Given this list of marker genes SFRP4, GPATCH2, CALD1, PLPP1, DUSP6, PRPSAP2, OSTF1 (osteoclast stimulating factor 1), CLECL1P, AP1S2, HECW2, TMEM192, S100P (NCBI Gene Id 6286), PTPRN2, SLC25A15, GAB2, PTGER2, CELF6, MACROH2A2, RXRA, SAMD3, RNF213-AS1, IKZF2, LIMS2, CLDN5, HRH1, TMEM71, TESPA1, PTEN, ABHD6, NT5C3B (NCBI Gene Id 115024), IL4R, ALX4, TIMP1, ETV3, KRT1, CCDC178, IL10RB, NNT, DLG5, RUNX1, PTPN14, RRS1, CCNT2-AS1, PECAM1, LINC00265, C1QTNF7, DIPK1A, SPINDOC, RNF125, ABHD8, VSIG10L, DACH1, TPRG1, BIN2, LONRF2, CDH1, SMYD2, CEACAM5, SPINT2, DCBLD1, ADAP1, TBC1D22A-AS1, C12orf75, PDCD4-AS1, BCL2A1, FAM171A1, DYNC2LI1, CAMSAP3, MMP1, FRY-AS1, PABPC4L, NSUN3, LETR1, CFAP97D1, CES4A, PPP1R14A, TAOK1, NMB, MID1, ACBD5, EXOC3, OXCT1, ENSG00000237250, ADAM29, NXN, TNNI3K, HMGCS2, EVI2B, HTATSF1P2, KDM2B, VCL, ZNF423, RAB27B, ADIPOR2, PTPN3, CLCC1, UBASH3A, CYTOR, FN1, PHF10, BBS5, TP53BP2, GPR183, RASSF2, IFFO2, MAL, IGSF3, CTSL, RHPN2, NARS2, IGSF11, NIPA1, TTC38, FBXO33, PLXDC1 (plexin domain containing 1), RGS2, CCDC162P, MGST3, ITM2C, AUTS2 (activator of transcription and developmental regulator AUTS2), MYH8, RCN2, PRPF18, PDE9A, ATP6V0A2, PABPC5, MRPS26, SLC2A11, PLA2G4A (phospholipase A2 group IVA), ARHGAP25, EDNRB-AS1, SLC40A1, AGAP12P, HACD3, DENND4C, TNFSF11, LRRC32, GSTT1, RAB30, OTUD7A, LEKR1, C15orf62, CFAP299, ST8SIA4, ABAT, TMCO2, IGFBP1, GPR146, PDE7B, CCL22 (C-C motif chemokine ligand 22), GAD1, FDXR, COG3 (component of oligomeric golgi complex 3), LINC02523, TMEM273, LINC02481, CTSC, ALMS1P1, ACTR3C, HS1BP3, GPCPD1, ALAD, CD93, PPARG, RPN2, GDE1, ST7-AS1, KRTAP2-1, NFIL3, DANCR, SLC9A9, SLC39A8, CCL17, ST3GAL1, GAB3, ELAPOR2, RAP1GAP2, AOAH, DLC1, GLTP (glycolipid transfer protein), TMED5, BCL2L11, GPR18, CD96, HSD17B7P2 (hydroxysteroid 17-beta dehydrogenase 7 pseudogene 2), GATA3 (GATA binding protein 3), PLCL1, MAOA, POLE4, CREG1, SLC25A23, LIMA1, NVL, IL10RA, C1orf162, here is a description of the gene set: species: Homo sapiens from publication Elo LL, Järvenpää H, Tuomela S, Raghav S, Ahlfors H, Laurila K, Gupta B, Lund RJ, Tahvanainen J, Hawkins RD, Oresic M, Lähdesmäki H, Rasool O, Rao KV, Aittokallio T, Lahesmaa R (PMID 20620947) Human Gene Set: GSE17974_IL4_AND_ANTI_IL12_VS_UNTREATED_48H_ACT_CD4_TCELL_UP The aim of this dataset was to study in detail the transcription kinetics initiated by cytokine IL-4 in early differentiation of Th2 cells. Genes up-regulated in comparison of CD4 T cells treated with IL4 and anti-IL12 at 48 h versus the untreated cells at 48 h.